The following is a description of a gene set: Human Gene Set: KEGG_MEDICUS_REFERENCE_CGAS_STING_SIGNALING_PATHWAY cGAS-STING signaling pathway. Pathway ID: N00395. Pathway type: Reference. Pathway class: nt06520 CGAS-STING signaling. Pathway Definition from KEGG: DNA -> CGAS -> cGAMP -> STING1 -> TBK1 -> IRF3 => (IFNA,IFNB) studied in species Homo sapiens, and this is the list of marker genes: IRF3, IFNA6, IFNA5, CGAS (NCBI Gene Id 115004), IFNB1, IFNA21, IFNA13, IFNA16, IFNA10, TBK1 (NCBI Gene Id 29110), IFNA2, IFNA7, IFNA8, IFNA4, IFNA14, IFNA17, IFNA1, STING1